The following is a description of a gene set: species: Mus musculus from publication Cui A, Huang T, Li S, Ma A, Pérez JL, Sander C, Keskin DB, Wu CJ, Fraenkel E, Hacohen N (PMID 38057668) Genes positively differentially expressed in cell type: ILC (innate lymphoid cell) upon treatment with cytokine: TL1A in mouse lymph nodes in vivo. Cytokines mediate cell-cell communication in the immune system and represent important therapeutic targets. A myriad of studies have highlighted their central role in immune function, yet we lack a global view of the cellular responses of each immune cell type to each cytokine. To address this gap, the authors created the Immune Dictionary, a compendium of single-cell transcriptomic profiles of more than 17 immune cell types in response to each of 86 cytokines (>1,400 cytokine-cell type combinations) in mouse lymph nodes in vivo. A cytokine-centric view of the dictionary revealed that most cytokines induce highly cell-type-specific responses. For example, the inflammatory cytokine interleukin-1β induces distinct gene programmes in almost every cell type. A cell-type-centric view of the dictionary identified more than 66 cytokine-driven cellular polarization states across immune cell types, including previously uncharacterized states such as an interleukin-18-induced polyfunctional natural killer cell state. Mouse Gene Set: CUI_ILC_TL1A_RESPONSE_UP, and this is the list of marker genes: Or13a17, Icam1, Cd74, Edem1, Mbp, Mrpl3, Mir155hg, Kdm4b, Il4i1, Psme2, Cd83, Tmsb10, Ppip5k1, Calr, Gzmc (granzyme C), Cd70, Batf, Btla